The following is a description of a gene set: The 10 subgenomic mRNAs of human respiratory syncytial virus A (hRSV A) are translated into 11 proteins. Except for the M2 mRNA, each mRNA encodes one distinct protein. The two overlapping open reading frames (ORFs) of the M2 mRNA encode proteins M2-1 and M2-2. The M2-1 product of the M2 gene is a transcription processivity factor, while the M2-2 product of the M2 gene is a nonstructural protein that regulates the switch between transcription and genome replication. The N mRNA encodes the nucleoprotein, which forms decameric and hendecameric rings around which viral genomic RNA is packaged. The L and P mRNAs encode the large polymerase subunit and the phosphoprotein polymerase cofactor subunit, respectively, of the RNA-dependent RNA polymerase complex (RdRP). The SH, G, and F mRNAs encode three proteins that are embedded in the viral envelope: small hydrophobic protein, attachment protein, and fusion protein, respectively. The secreted isoform of G protein (sG), involved in mediation of immune evasion, and the truncated form of SH (SHt), are translated from G mRNA and SH mRNA, respectively, through the usage of an alternative start codon. The NS1 and NS2 genes encode nonstructural proteins that function together to inhibit apoptosis and interferon response in infected cells. For review, please refer to Battles and McLellan 2019. Reactome Pathway: Translation of respiratory syncytial virus mRNAs species: Homo sapiens part of: Respiratory syncytial virus (RSV) genome replication, transcription and translation, and this is the list of marker genes: M2-1, L, N, Human respiratory syncytial virus A2, complete genome, G, 1B, M, SH, P, M2-2, F, 1C